The following is a description of a gene set: Myofibro 1 Human Gene Set: HE_LIM_SUN_FETAL_LUNG_C0_MYOFIBROBLAST_1_CELL from publication He P, Lim K, Sun D, Pett JP, Jeng Q, Polanski K, Dong Z, Bolt L, Richardson L, Mamanova L, Dabrowska M, Wilbrey-Clark A, Madissoon E, Tuong ZK, Dann E, Suo C, Goh I, Yoshida M, Nikolić MZ, Janes SM, He X, Barker RA, Teichmann SA, Marioni JC, Meyer KB, Rawlins EL (PMID 36493756) species: Homo sapiens, and this is the list of marker genes: DACH2, NOTUM, C1QTNF5, CXCL14, NKD1, PTGER2 (NCBI Gene Id 63381), CTXND1, CT45A7, PRAG1, ZEB1, RGN, PTCH1, TMEM100, FENDRR, SLC4A4, WNT5A, EYA4, SYT17, SEMA3C (NCBI Gene Id 222200), RHCG, MID1IP1, CPED1, TAB2, RASL11B, HTRA1, RAI2, MMGT1, IGF1, CT45A1, MYOCD, PAG1, SYT1, REEP1, SLC26A2, MT1X, MTUS1, IGSF1, MYH11, ARHGAP6, INTS6L, SLFN12L, ENC1, TPST2, CT45A9, CT45A2, CT45A5, SLC9A6, WNT11, CT45A3, ZNF536, STC1, JCAD, PLPPR4, MSANTD4, RNF43, MT1E, CT45A8, CT45A10, CT45A6, ETV5, SNAI1, KCNK17, ADAMTSL2, PROM1, ANO4 (NCBI Gene Id 121601), ACTG2, LEF1, THBD, PCSK5 (proprotein convertase subtilisin/kexin type 5)